The following is a description of a gene set: Mouse Gene Set: GOBP_POSITIVE_REGULATION_OF_TRIGLYCERIDE_LIPASE_ACTIVITY studied in species Mus musculus Any process that increases the activity of triglyceride lipase., and this is the list of marker genes: Gpihbp1, Nr1h2, Apoc2, Nr1h3, Apoc2l, Apoh, Lmf1, Apoa4, Pnlip, Apoa5 (apolipoprotein A-V)